The following is a description of a gene set: Human Gene Set: GOBP_MOLTING_CYCLE studied in species Homo sapiens The periodic casting off and regeneration of an outer covering of cuticle, feathers, hair, horns, skin, etc., and this is the list of marker genes: FST, KRT83, SOX18, INHBA, PTCH2, NIPBL, PER1, ALX4, LHX2, LDB2, KRTAP4-3, PLA2G10, APCDD1, KRT33B, KRTAP4-9, PIAS4, SAV1, CTNNB1 (catenin beta 1), IGFBP5, FOXI3, TERT, CD109, DSG4, LRP4, RBPJ, ACVR1B, CLOCK, TP63, EGFR, NUMA1, FGFR2 (fibroblast growth factor receptor 2), ZMPSTE24, KRTAP4-8, NF1, VANGL2, KRT71 (keratin 71), TNF, TNFRSF19, WNT10A, GNAS, DNASE1L2 (deoxyribonuclease 1 like 2), EXT1 (exostosin glycosyltransferase 1), FOXQ1, GLI2, HPSE, MPZL3, MYSM1, PKP3, SPINK5, KRT84, PPP1R13L, NOM1 (NCBI Gene Id 93130), DSC1, PUM2, KRTAP4-5, GAL, FOXN1, KRT14, MSX2, HDAC2, ERCC2, EPS8L3, TGM3, FOXE1, FZD3, NOTCH1, KRT27 (keratin 27), RELA, TFAP2C, TRADD, LGR4, SMAD4 (SMAD family member 4), TRPV3, ZDHHC21, EDA, SOX21, TSKU, TSPEAR, BCL2, SHH, FA2H, LRIG1, LAMA5, FERMT1, NSDHL, FGF10, TMEM79, INTU, NSUN2, KRT17, NAGLU, HOXC13, KRT25, ATP7A, SMO, SOS1, TGFB2, GORAB, SNAI1, DKK1, SOX9, FZD6, EDAR, WNT5A, WNT10B, LDB1, NGFR, FUZ, HDAC1, DLX3, FARP2, BMAL1, SOSTDC1, PDGFA (platelet derived growth factor subunit A), TRPC4AP, KRT16, KRT28, COL6A1 (collagen type VI alpha 1 chain), CDH3, LGR5, FGF7, DKK4